The following is a description of a gene set: Mouse Gene Set: GOBP_CELLULAR_EXTRAVASATION The migration of a leukocyte from the blood vessels into the surrounding tissue. species: Mus musculus, and this is the list of marker genes: Plcb1, Golph3, Cxcl12, Itga4, Ccl2, Itgam, Ccl21d, Mdk, Vcam1, Jam2, Podxl2, Trem1, Add2, Ripor2, Thy1, Crk, Adam8, Itgb1, Abr, Ccl21f (C-C motif chemokine ligand 21F), Fut9, Itgb2l, Fut4, Elane, F11r, Pdgfd, Icam1, St3gal4, Med23, Ptger4, Fer, Bcr, Ccl21b (C-C motif chemokine ligand 21B (leucine)), Fut7, Pecam1, Jaml, Ccl5, Sirpa, Sele, Itgb2, Selplg, Spn, Capn1, Sell, Cd177, Gp1ba, Prtn3, Il27ra, Jam3, Madcam1, Ptger3, Lep, Chst4, Ccl28, Itgal, Cd99l2, Trim55, Itga1, Pawr, Lyve1 (NCBI Gene Id 67461), Gcnt1, Ext1, Ccr2, Fadd, Ager, Ccl21a (NCBI Gene Id 18829), Chst2, Ripk3, Ccl25, Trem3, Rock1, Itgb7, Cx3cr1, Cd47, Ccl21e, Ptafr, Crkl (v-crk avian sarcoma virus CT10 oncogene homolog-like), Selp, Tnf, Il1r1, Plvap